Given this list of marker genes MXD3, FGB, CS, LINC00622, NACAD, ATP8B2, CLDN10, KRTAP9-3, TMEM105, CPT1C, LINC00906, LDC1P, MAK, ONECUT3, SEMA3A (semaphorin 3A), ASB16, COL4A1, GFI1, MYPOP, RARRES2, TWIST1, SMAD9, CCNYL7, IZUMO1, EDN2, ATP10B, NUPR1, SNX15, OAS1, GULP1, MEF2D, VSIG10L2, XIRP1, BOD1L2, HCG4B, ZNF767P, L1CAM, FITM1, KNCN, PYGO1, MYLK2, ZCCHC18, SLC16A8, LRIT1, TIMM8A (NCBI Gene Id 84782), RAB3C, HMGCS2, AGBL5, CA7, SLC22A25, CDC42EP2, MROH6, RALGPS1, SH3BGRL2, EOMES, FXN, STOML3, KDM5D, HSPB3, SERPINB9P1, S100Z, LRFN1, TNFRSF19, CST6, PRM3, GPR161, IGFBP3, DEFA4, ZNF621, TRPC2, PRSS37, WWC2-AS2, OR51E2, HRG, CALHM4, SSMEM1, STYK1, ZNF354C, EDNRB-AS1, POU5F2, GUCY2D, GPR176, LETM2, DKK4, BTNL9 (NCBI Gene Id 153579), NEU4 (neuraminidase 4), LINC02693, ZNF137P, CFAP45, NHEG1, ABCC6, USP28, ZNF843, SCARA3, FLRT1, TTC36, CALN1, PRSS54, LRRC4C, POLQ, WNK4, PLXDC1 (plexin domain containing 1), EPOR, BMP8A, TCP10L3, SERTAD4BP, SLC35F1, APOB, CSMD2, CA12, KRT76, MEIOC, PYCR1, FAXC, IGF2BP2-AS1, CPN2, PHACTR2-AS1, C5orf47 (NCBI Gene Id 133491), PER3P1, IL6ST-DT, MLN, ZNF776, NRARP, LRWD1, KDM2A, DRAIC, PLEKHH1, ENSG00000204684, SERPINA10, ZFP41, CYP3A7, ACKR3, JDP2, CADPS2, RCAN1, MTCL3, SCYL3, SCN11A, FAM106A, DPPA4 (NCBI Gene Id 55211), TUBGCP5, AVP, TANC1 (tetratricopeptide repeat, ankyrin repeat and coiled-coil containing 1), SIRT1, PKD1L1, TAF1B, NKD2, RPL13AP17, METTL27, CA5A, VXN, PHACTR1, DVL1, RFX6, BSPRY, FOXR2, LMX1A, MAP7D2, PCDHGA8, RTP1, LINC00592, TSNARE1, TSPAN6, ZNF443, RPS4Y1, INHBB, GTPBP3, PWAR5, SUGT1P1, TBC1D29P, CACNG7, SFMBT2, GPX2, PRSS16, SLC22A23, CGN (NCBI Gene Id 57530), HORMAD1, LINC00698, DUSP15, KRTAP7-1, DNAJB7, KRTAP5-2, CALML5, HES2, PAQR6, OTOS, OSTCP1, ADGRB2, CSRNP2, PLLP, here is a description of the gene set: Genes down-regulated in CD8 T effector cells during chronic infection with LCMV-Clone 13: day 6 versus day 15. During acute viral infections, naïve CD8+ T cells differentiate into effector CD8+ T cells and, after viral control, into memory CD8+ T cells. Memory CD8+ T cells are highly functional, proliferate rapidly upon reinfection and persist long-term without antigen. In contrast, during chronic infections, CD8+ T cells become “exhausted” and have poor effector function, express multiple inhibitory receptors, possess low proliferative capacity, and cannot persist without antigen. To compare the development of functional memory T cells with poorly functional exhausted T cells, we generated longitudinal transcriptional profiles for each. Human Gene Set: GSE41867_DAY6_VS_DAY15_LCMV_CLONE13_EFFECTOR_CD8_TCELL_DN studied in species Homo sapiens from publication Doering TA, Crawford A, Angelosanto JM, Paley MA, Ziegler CG, Wherry EJ (PMID 23159438)